Given this list of marker genes TCF3, SMC2, PIP5K1A, APOA5, HSPD1 (NCBI Gene Id 56733), PSTPIP1, ACVR2A, CRYGD, S100A6, MAD2L1, TYROBP, ZFP62, ERF, DHRS3 (dehydrogenase/reductase 3), UBAP2, FEM1A, FAM13B, CDK16, UBE2C, CKMT2, MMP12, SMAD7, GGH, PRKACB, GPN1, MOV10, PUM2, STAT4, KPNA1, NPM3, GCM2, UBA3, CASP2, AREG, OSTF1, SEMA4D, B3GALT1, H6PD, TAF6, MAT2A, CBFB, TNPO3, MYADM (myeloid associated differentiation marker), TCL1A (TCL1 family AKT coactivator A), LTA4H, NMD3, OGT, ABCB1, WDFY2, PGLYRP1, EPRS1, SIRPA (NCBI Gene Id 96784), BHLHE40, C9orf85, ANXA10, HMOX2, EIF1B, RPS6KA1, KLHL7, ZDHHC16, SRY, HNRNPUL2, GABRG3, PRKD3, CMIP, TRDMT1, ALPG (NCBI Gene Id 251, alkaline phosphatase, germ cell), SFRP2, TIAL1, NUP50, AP1G1, BTK (Bruton tyrosine kinase, NCBI Gene Id 695), MTM1, SFR1, PRUNE1, ZMYM4, ACR, XRCC5, TEAD2, PRPS1, ZNF444, CYBC1, DDX24, PPT2, PBRM1, SET (NCBI Gene Id 6418), SPAST, S100A4, KLF3, MAGOH, DDR1, COPG1, CDH11, MED11, MED20, PLEKHA1, ITGA7, RGS14, NOP2 (NCBI Gene Id 4839), DCAF13, HOXB9, KRAS, PLXND1, CPSF7, IDI1, ZRANB1, CSNK2A2, MVD (NCBI Gene Id 4597), SYPL1, MGST2, PDHA2, EEA1 (early endosome antigen 1), ANKH, FKBP3, SLC5A1, RELN, DTX1, TTC33, EIF4A2, GCNT1, PRKD2, RDH11, TCERG1, ARHGEF1, B4GALNT1, NME1, USP21, HOMER3, SURF6, DLK1, DNAJA1, ARHGAP9, SMAP2, CNOT6L, SRSF7, IL7R, ADGRL1, WNK1, CH25H, NEK2, QKI, PSMB1, LRRC8A, MRTFA, RHOQ, SRRM1, RBBP4, IFI27L2, PKLR, CRYBG1 (crystallin beta-gamma domain containing 1), PARP16, ZNF292, LARP7, HOXA3, RTL6, TENT5A, TRIM3, DDX1, PRKCB, TRIM11, ERGIC1, BMP8B, ADCYAP1, CDC5L, RORA, CIB1, ESRRA, NUDC, MAP3K1, TPM3, USP1, CNOT1, ARF3, UHMK1, APP, FDFT1, TMT1A, KANSL2, MSN, RPL15, RTN1, BIRC6, RIN2, STK10, SLC31A1, FCHO1, PAXBP1, LORICRIN, DPYSL2, GFI1, MAS1, RMND5A, LIMD1 (NCBI Gene Id 8994), ZRANB2, HSPH1, WDR26, HMGCR, NCOA4, COPB1, OGG1, here is a description of the gene set: Genes down-regulated in comparison of CD8 dendritic cells (DC) versus CD4- CD8- DCs. from publication Edwards AD, Chaussabel D, Tomlinson S, Schulz O, Sher A, Reis e Sousa C (PMID 12816982) The functional relationships and properties of different sub-types of dendritic cells (DC) remain largely undefined. We used a global gene profiling approach to determine gene expression patterns among murine splenic CD11c high DC subsets in an effort to better characterise these cells. studied in species Homo sapiens Human Gene Set: GSE339_CD8POS_VS_CD4CD8DN_DC_IN_CULTURE_DN